The following is a description of a gene set: The chemical reactions and pathways resulting in the breakdown of monosaccharides, polyhydric alcohols containing either an aldehyde or a keto group and between three to ten or more carbon atoms. species: Homo sapiens Human Gene Set: GOBP_MONOSACCHARIDE_CATABOLIC_PROCESS, and this is the list of marker genes: ALDOB, RBKS, FUT9, PFKFB2, HSD17B14, FUT5, GLYCTK, LRP5, ENO3, TKTL1, GLB1L2, BAD, MPI, PGM1, ACTN3, MIR210, GLB1, BCL2L13, ADCY10, PKM, TKFC, FUT1, PFKP, NUDT5, HK3, ENO1, PFKM, GLB1L3, FUT10, TP53, GALK1, PFKL, FOXK2, TPI1, FUT7, PGK2, FOXK1, PGAM1, FUT2, GLB1L, GALE, GPI, PGAM2, ENO2, TIGAR, HK2, GCK, XYLB, FUT8, FUT4, GALM, LDHA, HK1, PGK1, DHDH, FUT6, GALT